Given this list of marker genes HES6, CA5B, MLH3, XRCC3, VILL, NME3, SPNS3, UNC13B, FAM135B, THADA (NCBI Gene Id 63892), DTX4, TWF2, PPIE, LRRC73, SLC25A38, CCL24, RGL1 (NCBI Gene Id 23179), JUND, ACTR1A, TXNL4B, ZCWPW2, EIF2B4, VMA21, GPR179, AMELX, CHPF, TUT1, PDCD1, GPR63, MRPL19, KIF21B, ERLEC1, PDSS2, FABP7, NDUFS5, NEUROG3, ATP8B2, C18orf21, WDR38, CHST14, TMEM86A, TNNI2, RPS10, BRSK1, ZNF169 (NCBI Gene Id 7722), DUS3L, SLC19A2, FRMD4B, PRKRA, CLNS1A, IL22RA2, ABCG4, RAB11FIP4, CACNA1C, COL25A1, PEX11B, OXT, CD180 (NCBI Gene Id 4064), ENTPD6, TUBA1B, KCNAB3, POU2AF1 (POU class 2 homeobox associating factor 1), CCR5, ZNF768, USP24, PI4K2A, C12orf57, PKDREJ, DGKH, UBAC2, MAPKAP1, DUSP19, TRRAP, LDLRAD3, SDHAF1, NCOA2, UROS, ABHD1, FA2H, IL17RC, NFKBIL1 (NFKB inhibitor like 1), CYB5R3, TRIM65, ZFP57, ATP10A, FXN, BIRC7, ANAPC16, OXCT2, LDAH, MYCBP2, FAM222A, RBFOX2, COL4A3, MTHFD1, MCRIP2, AIP, MPV17L2, ANKRD46, ABI3, CNIH2, GBP6 (guanylate binding protein family member 6), MARVELD1, CPLANE1, HMG20A, PTGDR, RIN2, METTL27, IGSF21, PBX1, NRP2, C2CD4B, NDRG3, FKBPL, C11orf87, HOOK1, RASL10B, CXorf38, BCKDHB, PIERCE2, ERCC5, ZBTB45, CADM3, ANKMY2, ZNF32, RPAP2, PDE7A, ARHGAP10, CDC34, EMP3, KCTD13 (potassium channel tetramerization domain containing 13), KIF27, SAMD1, FASTKD1, YJU2, FRRS1, TMEM191C, PCNX3, CAMK2B, MIF, SFXN2, NKX2-3, C17orf99, SLC22A2, PPP1R18, TUBB6, RPUSD1, KLK5, LYPD3, BBS10, RBBP5, KIF2C, PDP2, IDS, NONO, KCNQ1OT1, ZBTB7B, FAM3C, IFNA1, HJURP, KRTAP20-2, VAMP4, SSBP1 (NCBI Gene Id 6742), PRSS56, SVIL (NCBI Gene Id 6840), ATE1, ATP9B, LRCH3, ECHDC1, SNX7, IGBP1, LARGE1, RBL1 (RB transcriptional corepressor like 1), IFIT2, RTEL1, STAT1, TIGD2, DOK7, ASB1, GNGT2, GALNT16, GSR, SRBD1, SLC24A2, NPLOC4, RHBDD3, NAPEPLD, SOCS1, CYP2D6, HOXC10, MAMDC4, PIMREG, DMRT3, FUT10, HERC2, DOCK2, SESN3 (NCBI Gene Id 143686), PLPP6, MS4A15, C19orf47, here is a description of the gene set: Genes up-regulated in nuocytes: control versus treated with IL7 and IL33. Nuocytes are a recently described cell that responds to both IL-25 and IL-33 and produce high levels of IL-13 and IL-5 Human Gene Set: GSE25890_CTRL_VS_IL33_IL7_TREATED_NUOCYTES_UP studied in species Homo sapiens from publication Neill DR, Wong SH, Bellosi A, Flynn RJ, Daly M, Langford TK, Bucks C, Kane CM, Fallon PG, Pannell R, Jolin HE, McKenzie AN (PMID 20200518)